Given this list of marker genes FXN, SPTAN1, SBF2 (SET binding factor 2), UBA1, VAMP1, HK1, SORD, SPTLC2, RAB7A, CADM3, DNAJB6, TRPV4, TFG, UQCRC1, SETX, LITAF, VPS13A, EMILIN1 (NCBI Gene Id 25883, elastin microfibril interfacer 1), CCT5, ATL1, PMP2, NDRG1, ATXN1, SYT2, SIGMAR1, BSCL2, NEFL, SPTLC1, MPV17, TBCK, DHX16, HSPB8, ATL3, RNF170, MORC2, KARS1, ALS2, LMNA, GDAP1, RFC1, here is a description of the gene set: Human Gene Set: HP_ABNORMAL_PERIPHERAL_ACTION_POTENTIAL_AMPLITUDE An anomaly in the magnitude of the action potential along a peripheral nerve, that is, of the rapid rise and fall of the electrical membrane potential of the nerve. Abnormal peripheral action potential amplitude studied in species Homo sapiens